The following is a description of a gene set: This event has been computationally inferred from an event that has been demonstrated in another species.<p>The inference is based on the homology mapping from PANTHER. Briefly, reactions for which all involved PhysicalEntities (in input, output and catalyst) have a mapped orthologue/paralogue (for complexes at least 75% of components must have a mapping) are inferred to the other species. species: Mus musculus Reactome Pathway: RNA Polymerase II Transcription electronically inferred by orthology from the curated human pathway part of: Gene expression (Transcription), and this is the list of marker genes: Prelid1, Psma4, Zfp946, Med1, Ccnh, Esr1, H2ac23, Psmc1, Zfp641, Psmb7, Zkscan3, Zfp606, Zim1, Taf11, Gm45871, Cox4i2, Rbbp7, Rnf111, Zfp688, Prdm9, Nr2c2, Mre11a, Cul1, Csnk2b, Taf8, Prdx1, L3mbtl2, Cox5a, Gtf2h4, Zfp989, Pax5, Cenpj, Arnt2, Ell2, Gata3, Nr3c1, Zfp582, H2bc12 (H2B clustered histone 12), Cradd, Sin3a, Cdkn1a, Rfc3, Zfp551, Cited1, Supt5, H3c4, Zfp655, Gtf2f2, Gata2, Zfp991, Nr0b1, Rxrb, Cnot4, Zfp119b, Top3a, H2bc9, Zfp420, Taf9b, Ppp1r13l (protein phosphatase 1, regulatory subunit 13 like), Zfp354a, H2bc7, Zfp273, Trp73, Zfp758, Phc1, Ercc2, Rpap2, Rad9a, Tcf7l1, Psmb5, Snrpf, Gtf2e1, Snrpg, Pou2f1, Zfp955a (NCBI Gene Id 77652), Eaf1, Nelfa, Ccnb1, Zfp934, H4c12, Zfp74, H2ac13, Zfp583, Zfp964, Zkscan8, Zfp1, Ash2l, Zfp740, Hus1, Bax, Snw1, Zfp418, Cnot10, Smarcc2, Nr1h4, Ctdp1, Yap1, Zfp746, Psmc2, Cdk1, H3c3, Zfp617, Zfp994, H2ac7, Taf7l, Zfp263, Gtf2f1, Psmd7, Ints13 (integrator complex subunit 13), Zfp456, Nelfe, H4c1, Hdac7, Pip4k2c, Actl6b, Tbl1x, Zfp35, H2ac24, Polr2b, Papola, AI987944, H2ac6, Esrrg, Zfp595, Plk2, Nr4a2, Taf15, Zfp750, Zfp764, Ppp2r1b, Bmi1, Ints2, Hnf4a, Zfp268, Nr2e1, Ccna1, Nek4, Zfp661, Ring1, Zfp12, Hnf4g, H4c2, Tfap2e, Lamtor5, Foxo6, Zfp175, Tcf7, Dna2, Men1, H3c11, Gtf2e2, H3c6, Zfp69, Rarg, Smarcd1, Zfp113, Psmd13, Zfp37, Ccng1, Higd1c, Notch3, Cited4, Myc, Zfp825, Rarb, Slbp, Zfp772, Zfp667, Ube2d1, Ints10, Zfp454, Kmt2b, H4c9, Cox6c, Zfp58, H2ac22 (NCBI Gene Id 319170), Zfp992, Bmal1, Casp2, Rabggtb, Blm, Wrn, Zfp987, Zik1, Psma5, Triap1, Cnot7, Ints7, Gm4924, Zfp385a, Zfp689, Rad1, Pou4f2, Snapc3 (small nuclear RNA activating complex, polypeptide 3), Cga, B020011L13Rik, H3c1, Max, Srrt, Zfp446, Zfp65, Mllt1, Psmb4, H2ac15 (H2A clustered histone 15), Smad1, Aurkb (NCBI Gene Id 20877), Phf20, Zfp799, H3c13, Tsc1, Zfp457, Hdac4, Ppm1d, Tpx2, H4c6, Ndufa4, Polr2k, Smad7 (SMAD family member 7), H2ac8, Zfp839, H2ac19, Zfp971, Zkscan5, Zfp995, Runx2, Smurf2, Prdx5, Mta2, Cdk4, Zfp786, Lbr, Tnks1bp1, Ubb, H2ac10, Zfp791, G6pdx, Rps27a, Kat5, H2ac12, H3c7, Foxo4, Steap3, Zfp747, Zfp770 (NCBI Gene Id 228491), Zfp715, Cdk5, Tfap2a, Zfp354b, Zfp458, Zfp317, Lamtor2, Taf7, Cbx6, Rictor, Ice2, Taf4b, Cycs, H4c8, Ppp1r13b, Zfp747l1, Zfp867, H2bc8, Zfp455, Foxp3, Taf6, Zfp759, Esrrb, Zfp703, Nr1i2, Zfpm1, Prkag1, Polr2a, Hdac11, H2ac11, Rbbp8, Sumo1 (small ubiquitin-like modifier 1), Ldb1, Polr2c, Zfp605, Supt4a, Ccne2, Tbx5, E2f7 (E2F transcription factor 7), Pcna, Smarcb1, Zfp61, Gm14325, Cdk13, Nr5a1, Prmt5, Zfp940, H4c3, Rsl1, Ercc3, H4c14, H2bc3, Wdr33, Tcea1, Tcf3, Ywhah, Nr4a3 (nuclear receptor subfamily 4, group A, member 3), Ing2, Gls2, H2bc15, Psmc4, Zfp386, Zfp566, Snapc1, Zfp955b, Elf1, Krba1, Zfp775, Gtf2a1, Zfp930, Polr2l, Psmd6, Gm5141, Zfp677, Zfp712, Ddit4, Maged1, Psma3, Thrb, Gtf2h2, Sesn2, Pou2f2, Zkscan4, Arid1a, Psmb6, Lamtor4 (NCBI Gene Id 66096), Mapk11, H2ax, Smarcd2, Scmh1, Banp, Zfp947 (NCBI Gene Id 210853), Zfp942, Zfp990, Mapk14, Zfp982, Ywhae, Trp53, Psmd12, Zfp763, H4c11, Nr2f6, Gm7072, Igfbp3, H4c17, Txn1, Aff4, Mapk3, Psmd1, Polr2e, Tgfb1, Cdk12, Psma7, AU041133, Pcgf2, Zfp931, Lsm11 (NCBI Gene Id 72290), Nr1d2, Zfp212, Bard1, Tead2, Cbfb, Zfp708 (NCBI Gene Id 432769), Cbx2, Zfp729a, Zfp738, Zfp112, Zfp691, Rbbp4, H3f3a, Pparg, Rngtt, Zfp14, Psmc3, H3c15, Nr2f1, Gadd45a, H3c8, Psmc6, E2f6, Taf13, Gtf2b, Zfp493, Rabggta, Cox4i1, Chek2, Ar, Trp63, H2ac4, Zfp46, Esr2, Ctnnb1, Zfp324, Cox8a, Sgk1, Cox6a1, Tbp, Nrbf2, Pcgf6, Cox8c, Npm1, Cdk8, Zkscan7, Smad3, H2bc1, Supt16, Atad2, Zfp445, Gm14391, Zfp169 (NCBI Gene Id 67911), Leo1, Daxx, Tcf7l2, Zfp90, H2bc13, Prkag3, Psmc5, Tead4, Smarcc1, Cpsf3 (NCBI Gene Id 54451), H2bc11, Cbx4, Cpsf1, Rheb, Npas4, Zscan25, H2ac20, Rxrg, Sfn, H4c18, Ncor2, Zfp647, Eaf2, H3c10, Nr0b2, Zfp473, Taf5, Zfp959 (NCBI Gene Id 224893), Cdkn1b, Zfp872, H2az2, Gpx2, H3c2, Brpf1, Psma2, Tfdp1, Ep300, Setd1a, Zfp788, Psma1, Zfp619 (NCBI Gene Id 70227), H4c4, Wwtr1, Yaf2, Iws1, Pdpk1, Vdr, Clp1, Txnrd1, Gm10033, H2bc22, Cox7c, Hdac10, Zfp39, Map2k6 (mitogen-activated protein kinase kinase 6), Zfp804b, Polr2f, Zfp429, Nuak1, Lmo2, Rnmt, Lamtor1, Tgif1, Cdc25c, Ctr9, Rpa1, Gata1, Rraga, Zfp938, Nabp2, Zfp141, Zfp94, Smarca2, Zfp202, Brca1, Zfp811, Zfp286, Zfp808, Rragc, Pip4p1, Hdac8, Rara, Taf12, Ccne1, Nbn, Ehmt1, Ezh2, Cox6a2, Taf1, Zfp600, Zfp784, Brpf3, Taf10, Cited2, Cbx8, Tfap2d, Nr4a1, Psma6, Fip1l1, Zkscan17, Rorb, Zfp27, Sirt1, Smarca4, Ints14, Zfp612, Polr2i, Zfp101, Serpinb13, Ints8, Atp1b4, Ccnd1, Zfp735, Cox7a1, Smurf1, Zfp383, Cox7a2l, Rorc, Tal1, Mapkapk5, H2ac1, Ints1, Mbd3, Zfp943, Hdac3, Dyrk2, H2bc27